Given this list of marker genes TNFRSF10B, NOL3, TNFRSF10A, FADD, CHEK1, HUS1, here is a description of the gene set: Apoptosis genes down-regulated by TP53 in HCT116 cells (colon cancer) treated with thymoquinone. species: Homo sapiens from publication Gali-Muhtasib H, Kuester D, Mawrin C, Bajbouj K, Diestel A, Ocker M, Habold C, Foltzer-Jourdainne C, Schoenfeld P, Peters B, Diab-Assaf M, Pommrich U, Itani W, Lippert H, Roessner A, Schneider-Stock R (PMID 18632613) Human Gene Set: GALI_TP53_TARGETS_APOPTOTIC_DN There are few reports describing the role of p53-dependent gene repression in apoptotic cell death. To identify such apoptosis-associated p53 target genes, we used the pro-oxidant plant-derived drug thymoquinone and compared p53+/+ and p53-/- colon cancer cells HCT116. The p53 wild-type (wt) status correlated with more pronounced DNA damage and higher apoptosis after thymoquinone treatment. A significant up-regulation of the survival gene CHEK1 was observed in p53-/- cells in response to thymoquinone due to the lack of transcriptional repression of p53. In p53-/- cells, transfection with p53-wt vector and CHEK1 small interfering RNA treatment decreased CHEK1 mRNA and protein levels and restored apoptosis to the levels of the p53+/+ cells. p53-/- cells transplanted to nude mice treated with thymoquinone up-regulated CHEK1 expression and did not undergo apoptosis unlike p53+/+ cells. Immunofluorescence analysis revealed that the apoptosis resistance in p53-/- cells after thymoquinone treatment might be conveyed by shuttling of CHEK1 into the nucleus. We confirmed the in vivo existence of this CHEK1/p53 link in human colorectal cancer, showing that tumors lacking p53 had higher levels of CHEK1, which was accompanied by poorer apoptosis. CHEK1 overexpression was correlated with advanced tumor stages (P = 0.03), proximal tumor localization (P = 0.02), and worse prognosis (1.9-fold risk, univariate Cox regression; Kaplan-Meier, P = 0.04). We suggest that the inhibition of the stress response sensor CHEK1 might contribute to the antineoplastic activity of specific DNA-damaging drugs.